The following is a description of a gene set: Genes predicted to be targets of miRBase v22 microRNA hsa-miR-3657 in miRDB v6.0 with MirTarget v4 prediction scores > 80 (high confidence targets). Human Gene Set: MIR3657 species: Homo sapiens from publication Chen Y, Wang X (PMID 31504780), and this is the list of marker genes: MMP13, SMUG1, NUFIP2, RAB4A, GNG10, GCSAM, SLC47A2, LILRA5, ERBB2, CIITA (NCBI Gene Id 4261), SLC12A3, MBNL2, FBXL16, ZNF350, ATF7IP, DDX20, DNAJC25-GNG10, ARRB1, NR4A2, PLXNA4, RBP3, PIGM, STARD13, DNAI4, DNAJC10, KIAA1958, CLIC1, AWAT1, ABLIM3, PPARGC1B, FGFRL1 (fibroblast growth factor receptor like 1), CFAP90, NLGN2, EBF1, RCBTB1, IQSEC1, ANKRD28, PDLIM3, CLCN4 (NCBI Gene Id 4412), KHDRBS1, BTRC, WSCD1, DMRTA2, DIRAS1, OSBPL7, RASEF, GALNT2, SHISA6, CYTH3, TBC1D13, ZNRF2, CNNM1, EFS, MED14, CHORDC1